The following is a description of a gene set: Lipofuscin, a generic term applied to autofluorescent lipopigment, is a mixture of protein and lipid that accumulates in most aging cells, particularly those involved in high lipid turnover (e.g., the adrenal medulla) or phagocytosis of other cell types (e g., the retinal pigment epithelium or RPE; macrophage). This term pertains if there is an increase in the neuronal accumulation of lipofuscin (also known as autofluorescent lipoprotein) more than expected for the age of the patient. Increased neuronal autofluorescent lipopigment Human Gene Set: HP_INCREASED_NEURONAL_AUTOFLUORESCENT_LIPOPIGMENT species: Homo sapiens, and this is the list of marker genes: CLN5, CLN3, PPT1, CLN8, CLN6 (CLN6 transmembrane ER protein), TPP1, DNAJC5, CTSD